The following is a description of a gene set: Golgi Cisternae Pericentriolar Stack Reorganization Human Gene Set: REACTOME_GOLGI_CISTERNAE_PERICENTRIOLAR_STACK_REORGANIZATION species: Homo sapiens, and this is the list of marker genes: BLZF1, RAB1A, PLK1, RAB1B, CCNB2, GOLGA2, MAPK1, GORASP1, MAPK3, RAB2A, CDK1, GORASP2, USO1, CCNB1